The following is a description of a gene set: species: Homo sapiens Genes predicted to be targets of miRBase v22 microRNA hsa-miR-6125 in miRDB v6.0 with MirTarget v4 prediction scores > 80 (high confidence targets). from publication Chen Y, Wang X (PMID 31504780) Human Gene Set: MIR6125, and this is the list of marker genes: TRIM41, BCORL1, EIF4EBP1, YTHDF2, KIAA0232, KIF6, MROH2A, SLC6A12, USP35